The following is a description of a gene set: Abstract: Trastuzumab-induced cardiotoxicity (TIC) is a common and serious disease with abnormal cardiac function. Accumulating evidence has indicated certain non-coding RNAs (ncRNAs), functioning as competing endogenous RNAs (ceRNAs), impacting the progression of cardiovascular diseases. Nonetheless, the specific involvement of ncRNA-mediated ceRNA regulatory mechanisms in TIC remains elusive. The present research aims to comprehensively investigate changes in the expressions of all ncRNA using whole-transcriptome RNA sequencing. The sequencing analysis unveiled significant dysregulation, identifying a total of 43 circular RNAs (circRNAs), 270 long noncoding RNAs (lncRNAs), 12 microRNAs (miRNAs), and 4131 mRNAs in trastuzumab-treated mouse hearts. Subsequently, circRNA-based ceRNA networks consisting of 82 nodes and 91 edges, as well as lncRNA-based ceRNA networks comprising 111 nodes and 112 edges, were constructed. Using the CytoNCA plugin, pivotal genes - miR-31-5p and miR-644-5p - were identified within these networks, exhibiting potential relevance in TIC treatment. Additionally, KEGG and GO analyses were conducted to explore the functional pathways associated with the genes within the ceRNA networks. The outcomes of the predicted ceRNAs and bioinformatics analyses elucidated the plausible involvement of ncRNAs in TIC pathogenesis. This insight contributes to a better understanding of underlying mechanisms and aids in identifying promising targets for effective prevention and treatment strategies. Mouse Gene Set: XIE_TRASTUZUMAB_CARDIOTOXICITY_LNCRNA_GENES from publication Xie S, Zhou N, Su N, Xiao Z, Wei S, Yang Y, Liu J, Li W, Zhang B (PMID 38577019) species: Mus musculus, and this is the list of marker genes: Tug1 (taurine upregulated gene 1), D130020L05Rik, 1700086O06Rik, Malat1, AI506816, Gm47512, Wt1os, Gm10602, 4933427E11Rik, 4930455M05Rik, Gm15886 (NCBI Gene Id 102637354), Dubr, A730020M07Rik, Gm15441, Mir155hg, Rian, Gm4419, Gm13715, Mypopos, Gm19689, C130026L21Rik, D330041H03Rik, 1700030M09Rik, Gm12454, Gm41396, Gm13944, Gm9828, Snhg16, Gm4681, Gm10570, Morrbid (NCBI Gene Id 100048565), Plet1os, Gm46565, Gm29050, 6330403L08Rik, Gm15577, 2010001A14Rik, 1110038B12Rik, 2010016I18Rik, 4632427E13Rik, Gm15327, Gm12977, Gm32184, Xist, 4932435O22Rik, Gm10658, Gm15581, D730003I15Rik, Zfp85os, 9530052E02Rik, Gm34006, 9930014A18Rik, 4933428P19Rik, 5033426O07Rik, Gm36723, Dleu2, 1810062O18Rik, 2610206C17Rik, Gm31152, 8430426J06Rik, 5530601H04Rik, Gm13166, Gm33682, BC065403, A530076I17Rik, Rmst, Rab10os, Gm36738, 0610039K10Rik, 1700093J21Rik, Terc, Gm805, Gm15247, D830032E09Rik, Gm33989, Hoxb3os, Snhg5 (NCBI Gene Id 72655), Gm14966, 2900089D17Rik, Gm34586, Chrna1os, 2310016G11Rik, Mir99ahg, Gm36535, Gm39377, Gm10032, Gm43305, 6330418K02Rik, Gm19554, Gm10382, Gm5577, Trmt61b, Snhg7os, 8430429K09Rik, E230029C05Rik, Mir100hg, 4933422A05Rik, 2810455O05Rik, Gm12963, Gm29183, A830082K12Rik, Etaa1os, 3632454L22Rik, Gm20619, Ino80dos, Gm2449, 2810403D21Rik, 2610307P16Rik, Hoxaas2, Ppp1r36dn, Gm17473, C030034L19Rik, 4932413F04Rik, Gm9922, Gm15802, 4933431E20Rik, D830036C21Rik, 9830144P21Rik, Gm35363, Gm29683, 4631405J19Rik, A230009B12Rik, Gm16169, Gm15942, 1110020A21Rik, 8030451A03Rik, Gm36756, D830026I12Rik (RIKEN cDNA D830026I12 gene), Gm35394, 9630014M24Rik, Ccdc34os, Ccdc142os, 1810019D21Rik, 4921513I03Rik, Gm31135, A930028N01Rik, Gm11008, Gm26608, A530020G20Rik, 4931413I07Rik, Ftx, Gm26684, Gm10638, 0610040B10Rik, AI480526, B130046B21Rik, Gm42047, Gm36236, 1300002E11Rik, Gm30938, 4933407I08Rik, 9530036M11Rik, Gm10603, 9330188P03Rik, Gm12354, Gm47918, E130307A14Rik, Gm13710, Gm12349, 6030443J06Rik, Gm11379, 4930538L07Rik, 4933406C10Rik, C030005K06Rik, F630040K05Rik, Gm10419